The following is a description of a gene set: Human Gene Set: GOBP_LATERAL_MESODERM_MORPHOGENESIS species: Homo sapiens The process in which the anatomical structures of the lateral mesoderm are generated and organized., and this is the list of marker genes: FOXF1, BMPR1A, TAF10, FGFR1 (NCBI Gene Id 84151), TBX20